Given this list of marker genes Samhd1, Dut, Itpa, Nudt15, Enpp1, Dctpp1, Smpdl3a, Nudt16, Ada, Entpd7, Enpp3, Entpd3, here is a description of the gene set: The chemical reactions and pathways resulting in the breakdown of a nucleoside triphosphate, a compound consisting of a nucleobase linked to a deoxyribose or ribose sugar esterified with triphosphate on the sugar. Mouse Gene Set: GOBP_NUCLEOSIDE_TRIPHOSPHATE_CATABOLIC_PROCESS studied in species Mus musculus